Given this list of marker genes PHB2, IL31RA, MAP2K6, DUSP13B, MAPK3, PRDX2, HSF1, FOXM1, GHRL, SH3RF3, MBP, PRKCZ, FGF9, MIR185, CAVIN3, SHANK3 (SH3 and multiple ankyrin repeat domains 3), ARRB1, IRAK3, TRPV4, SBNO1, PPM1L, RELL2, CCR1, PDGFRB, RNF41, TNF, NELFE, MAP3K20, GADD45B, RB1CC1, TENM1, NECAB2, CCL11, XBP1, KCNJ8, FGF6, ATP6AP2, AMBP, DDT, NRXN1, RAC1, IL6, NTF3, DUSP26, MYDGF, MADD, PLVAP, PSCA, MAP4K5, FLCN, NOTCH2, SPRY1, ERRFI1, PRMT1, CDK12, GPR183, ZFP36, MECOM, SEMA6A (semaphorin 6A), FGFR2 (NCBI Gene Id 2263), MAPK12, NAIP, PIK3R2, VRK2, HMGCR, CDK10, IGF2, ADORA1, MIR133B, PTPN22, PSMD10, MST1R, KARS1, MAPKAPK2, SEMA3A, ARHGAP8, FFAR4, PDGFC, LIF, EFNA1, PDE8A, FGF3, AGER, OR2AT4, TGFB1, NAMPT, CTSH, EDAR, RET, HGF, ADORA2A, PJA2, SPRED1, HIPK3, SYNJ2BP, APIP, STK39, WNT7B, THPO (thrombopoietin), WNT4, ELANE, CAV3, ALKAL2, YWHAE, IL1A, MAPK10, STK4, MAP2K5, NDRG2, NRK, IL34, CTNNB1, ENSG00000274276, CD36, RYK, FGF20, DUSP1, WNT7A, IGFBP4, STK3, GPR37, GRM4, SCIMP, TEK, MIR26A1, FGFR3, NPR2, LEMD2, CD44, DUSP29, APOE, HAND2, FGF17, DRD4, SMAD1, MIR519D, TNXB, PLCG2, SH2B3 (NCBI Gene Id 10019), MAPKBP1, PTGER4, MIRLET7B, AXIN1, NDRG4, BMP2, CSPG4, CDC42EP5, CHRNA9, DSC2, LAMTOR2, NHERF1, PAK3, SLCO3A1, NLRP12, PAK1, LILRB4, ITCH, GNAI2 (G protein subunit alpha i2), SEMA4C, NRP1, FGFR1, MEF2A, TRAF4, CALCR, KLHDC10, TLR4, DVL2, MAPKAPK5, MAP3K3, PTPRJ, TNIP1, SMAD3, WNT5A, FLT3, MIR138-1, CSF1R, CRIPTO, COPS5, DLG1, ADRB1, QARS1, NOD2, MIR23A (NCBI Gene Id 407010), STYXL2, GPBAR1, MIR483 (NCBI Gene Id 619552), IAPP, LMO3, FGA (NCBI Gene Id 2243), CCN2, BMP4, FOXO1, DAB2, CBS, KRAS, MAP2K4, HACD3, CYLD, CEACAM1, ID1, TAOK2 (TAO kinase 2), WWC1, MAP3K6, IL1B, GSTP1, PECAM1, HLA-DRB1, DKK1 (NCBI Gene Id 22943), LPAR3, MAP3K15 (mitogen-activated protein kinase kinase kinase 15), P2RY6, AVPR1B, NPHS1, GRM1, IL6R, MAP3K1, PRDM15, FAM83D, MAPK8IP1, TBC1D10C, NPNT, IRAK1, DOK5, ALKAL1, HESX1 (HESX homeobox 1), ACKR3, RASGRP3, GRIK2, SOX9, HMGB1, ADIPOQ, PIK3R5, DUSP8, FBXO21, KSR2, CCR5, PROK1, REN, TNFSF11, PTPN1, PLCB1, ROCK1, MIR145, DUSP7, PTPN7, AKAP13 (A-kinase anchoring protein 13), FLT4, ARRB2, PRKCA, NLK, DUSP5, CLEC7A, HRAS, FGF13, FPR2, RASGRF1, CRYBA1, YWHAZ, DRD1, P2RX7, PAFAH1B1, RIPK1 (receptor interacting serine/threonine kinase 1), RAP1B, ZC3H12A (zinc finger CCCH-type containing 12A), PDCD4, MOS (NCBI Gene Id 4342), MIR20A, MIR503, INS, FGF8, SH3GL2, DDR2, DACT1, KSR1, SIRPA, USP17L2, PAQR3, IL26, FSHR, GAS6, EGF, ROS1, TGFA, TAOK3, PLA2G5, GBP1, GPR101, MT3, RGS2, MIR21, NR2C2, STK38, NDST1, RRAS, TRAF6, FGF23, PTPN3, EPHB1, CRKL, MIR218-1, DSTYK, MAP3K12, PPARG, CDC42, HTR2A, MAPK8IP2, MAP3K21 (mitogen-activated protein kinase kinase kinase 21), TGFBR3, SHOC2, MIR24-1, IGF1R, BECN1, DVL3, CCM2, KIT, ERN1, LBH, ANGPT1, INHBA, SPI1 (NCBI Gene Id 6688), HTR2B, GBA1, PPP1CB, RAP1GDS1, RNF149, TP73, SMAD4, HIPK2, DIRAS2, PIK3CB, MIR126, JCAD, PTPRR, EPHA4, CCL3, GFRAL, FRS2 (NCBI Gene Id 10818), MAP3K19, MAPK1, MIR27B, SCG2, ALOX15, SERPINB3, FAS, ACTA2, FGF22, NOX4, GSDME, MIR181B1, CDON, WNK4, GPER1, LAMTOR1, CD27, TLR3, NMNAT1, ITGAV, IQGAP3, PTPRC, FGF14, MYOC, EDN3 (endothelin 3), ZFP36L2, VRK3, PLA2G2A, MIR221, CCN1, PDGFB, CCL21, GDF15, PP2D1, RAP2A, MIR92A1, MAP4K4, RELL1, RAPGEF2, TREM2, PRKD2, GPNMB, MAP2K2, PABPN1, CAMKK2, EPGN, IGFBP6, TBX1, ZNF622, RAP1A, ERCC6, APELA, P2RY1, SPRED2 (sprouty related EVH1 domain containing 2), RHBDD3, AVPI1, PLA2G1B, ZNF675, ADCYAP1, MAP3K7, ZDHHC17, SPRED3, PRKN, MIR200C, RANBP9, GH1, ADAM9, RCE1, DAXX, FGF12, MAPK13, NGF, FGG, ZFP36L1, MAP3K8, MARCO, APP, CCDC88C, TRIB1, MDFIC2, TAB1, GAREM1, PRDX1, ERBB4, GRM5, FGF2, PHB1 (NCBI Gene Id 5245), MAPK6, INAVA (innate immunity activator), SH3RF2, VEGFB, PRDM11, NPFFR2, S100A7, RIPK2, PYCARD, RAMP3, SORBS3, SERPINF2, ZDHHC9, GHR, NPY5R, DEFB114, ATF2 (activating transcription factor 2), RIT2, NPSR1, ERBB2, EPHA7, PRMT5, NBR1, SYT14P1, ADAM8, TRAF2, OPRM1, WNT16, TIRAP, NODAL, NEK10, HAVCR2 (NCBI Gene Id 84868), DUSP22 (dual specificity phosphatase 22), MINK1, ADRA1A, FAM3C, AKAP12, SOD1, CD81, CXCL17, MYC, SLC30A10, PRKCD, MAPK4, MBIP, LAX1, DBNDD2, C5AR1, PEBP1, LAMTOR3, MAPK8IP3, FGF7, CRK, DOK4, PHLPP1, FGF1, CDK5RAP3, NRAS (NCBI Gene Id 4893), CFLAR, BTN2A2, MIR133A1, DNAJC27, SIRT3, FGFR4, CDK1, NRG1, MAP1LC3A, CARTPT, BRAP, NOTCH1, ULK4, S100A12, DHX33, ERBB3, PAK2, TPD52L1, EPHA2, CD4, GPS1, TRAF7, CD2AP, FCRL3, MAPK14, WNK2, XIAP, ADRA2A, INPPL1 (inositol polyphosphate phosphatase like 1), GLIPR2, EZR, NOX1, PDGFRA, MEF2C, RNF13, EPHA8, PER1, RASSF2, CHI3L1, EGFR (epidermal growth factor receptor), RGS14, CD74, INSR, GREM1, PELI2, PTPN11, NFKB1, MEN1, SPRY4, CD24, C3orf33, ADRB3, PBK, C1QL4, GCNT2, PAK4, ARAF, TLR6, MAPK15, CRYAB, FGF21, IGF1, PEA15, TLR9, ADRA2C, SEMA7A, RPS6KA6, SPAG9, GRB2, TNFRSF11A, PIN1, MDFI, ADRA2B, DAB2IP, ITGB3, FGF19, MTURN, BRAF, ERP29, ATF3, EIF3A, F2RL1 (F2R like trypsin receptor 1), VEGFA, MARVELD3, RBX1, FZD7, EIF2AK2, HCRTR1 (NCBI Gene Id 3061), PTPN6, DAG1, CARD9, ABCC9, ACE2, ARL6IP5, JAK2, GPR37L1, MAP2K1, SASH1, MID1, GDF6, PDE6H, ANKRD6, PPEF2, WDR54, NTRK3, MIR205, CCR7, LAPTM5, DUSP19, KLB, MAP3K14, MAPK9, GRB10, GRAP2, OSM, DRD5, MAPKAPK3, ADRA1B, ITPKB, KDR, DENND2B, KL, FGF10 (fibroblast growth factor 10), MIR424, SLAMF1, DUSP3, MAP3K10, CAV2, SRC, DUSP4, IGBP1, MIF (NCBI Gene Id 4282), DUSP9, HTR2C, ARHGEF6, GPS2, MAP4K2, NOD1, TGFB2 (transforming growth factor beta 2), STUB1, PRKCE, IGFBP3, AIDA, NTRK2, PINK1, SOX2, PTPN2, LTBR, PTK2B, ZMYND11, BMPER, CCL19, BIRC7, MDFIC, IKBKB, MAPK7, ITGA1, FZD10, STYX, PKHD1, NKD1, C1QTNF1, PAK6, RAF1, APOA1, MAP3K9, GPR55, BANK1 (B cell scaffold protein with ankyrin repeats 1), FGF5, CAV1, FGF18, MIR181D, TRIM5, FN1, GADD45A, THBS1, HDAC3, ITGB1BP1 (NCBI Gene Id 9270), JUN, EPHB2, KLF4, POU4F2, MAP4K1, LRRK2, UNC5CL, STK40, DNAJA1, TNFRSF19, SH2D3C, DUSP15, PPIA, PDGFA, ABCA7, PPP5C, MYD88, MAP3K4, LGALS9, DRD2, STK25, NPPA, CIB1, LAT, LYN, SYNGAP1, PDCD10, BCAR3, PAK5, SYK (NCBI Gene Id 6850), SPHK1, MAP2K3, SPRY3, GCG, MAP2K7, MAP4K3, LPAR1, PIK3CG, BNIP2, NF1, DUSP2, FLT1, PIK3R6, PPP1CC, OPRK1, FCGR2B, DUSP10, TNIK, CHRNA10, CASR, F2R (coagulation factor II thrombin receptor), MAP3K13, NRTN, SH2D3A (SH2 domain containing 3A), ALOX12B, CD40, NCOR1, EDA2R, TMEM106A, MAPK8, FGF4, IRAK4, FBLN1, DSG3, CSK, CNKSR3, KLHL31, NLRP6, FGB, MIR27A, CX3CL1, PAGE4, FKTN, CRACR2A, SDCBP, HRH4, MFHAS1 (multifunctional ROCO family signaling regulator 1), DUSP16, PDE6G, PDGFD, AGT, ASH1L, EMILIN1, EPO (NCBI Gene Id 82670), UCHL1, NTRK1, IQGAP1, FGF16, SH3RF1, NPY, ROBO1, MIR181A2, SMPD1, LPAR2, LILRA5, RASGRP1, ICAM1, FBXW7, EZH2, ADRA1D, FERMT2, SPRY2 (NCBI Gene Id 10253), IL11, MAPK11, SBK2, PRXL2C, MAP3K5, NF2, ADRB2, GRAP, CHRNA7, TAOK1, TNFAIP8L3, GADD45G, CDH2, DUSP6, ROCK2, TLR7, DIRAS1, PDE8B, CBLC, EDN1, STRADB, TRIB3, SHC1, MAP3K11, LEP, CD300A, NENF, ARHGEF5 (NCBI Gene Id 7984), SLA, TPBG, AR, ABL1, MAP3K2, here is a description of the gene set: Human Gene Set: GOBP_MAPK_CASCADE studied in species Homo sapiens An intracellular protein kinase cascade containing at least a MAP kinase (MAPK). It starts with the activation of a MAP3K, and the consecutive activation of a MPK2K and a MAPK. The cascade can also contain an additional tier: the upstream MAP4K. The kinases in each tier phosphorylate and activate the kinase in the downstream tier to transmit a signal within a cell.